The following is a description of a gene set: Human Gene Set: MODULE_198 Genes in the cancer module 198. studied in species Homo sapiens, and this is the list of marker genes: HNRNPF, POLE, XRCC3, CBX4, GTF2I, PHLDA1, PSMC4, SNRPA1, HIF1A, KRT19, FOXD1, KATNB1 (NCBI Gene Id 10300), STAMBP, ZNF43, TOPBP1, NCBP2, TRIP13, PPP4C, CBX5, FKBP5, CENPF, CDC7, SLBP, MCM3, PSMA4, ZBTB25, MAZ, BRD2, CDC5L, MSX1, RNMT, RAD51D (RAD51 paralog D), CCNT1, E2F1, PRKDC (protein kinase, DNA-activated, catalytic subunit), TOP2A, TLX2 (T cell leukemia homeobox 2), CDK1, RFC1, CCNA2, NEK2, CEBPG, RAN, ZNF124 (NCBI Gene Id 7678), CHAF1B, RPA3, HNRNPR, BLM (BLM RecQ like helicase), NME2, FOXG1, CCNB2, CCNE1, UNG, TULP3, BARD1, RAD21, CCNB1, BLMH, NASP, NFATC4, PSMD2, RBBP7, CDC45, DDX23, ZWINT, HSF2, PSMA2, MSH2, DNMT1, ZNF195, ASAP2, RNF144A, POLR2D, FEN1, KRT6B, AP3M2, BMI1, KNTC1, SRSF2, MYCN, APEX1, SMARCC1, LRP8, CCND2, PTTG1, SRPK2, WEE1, PRPF8, LIG1, CALU, EWSR1, RFC5, SNW1 (SNW domain containing 1), NDC80, MAP2, SPDEF, MAFG, MLF1, MYBL2 (NCBI Gene Id 4605), CCNE2, CDKN1A, RBBP8, CDK7, HNRNPA3P1, CSE1L, DLX5, H2AZ1, ZIC1, ATF4 (activating transcription factor 4), PSMD10, PPP2R5D, HDAC2, PRIM1, PER1, MYC, DUSP5, ACTL6A, KRT17, AKT1, HMGN4, LMNB1 (NCBI Gene Id 445266), H2BC12, POLA1, SATB1, MYO18A, KIF23, H2AX, NAP1L4, NUP107, POU4F1, TENT4A, RCC1, SRSF6, CTCF, FANCG, CHEK1, DR1, CCNA1, CMPK1, TFAP2A, TAF6 (NCBI Gene Id 6878), RBBP4, PRIM2, UBE2A, RECQL4, CDK2, FOSL1, VPS72, RPA1, SRSF1, TRA2B, SSB, SETDB1, STK38, TBP, CDKN2C (cyclin dependent kinase inhibitor 2C), DDX17, NME1, MNDA, XRCC5, ILF2, TMPO, RAD51C, SAP30 (Sin3A associated protein 30), MAPK14, ZNF217, COIL, ZFP36L1, LIG4, CENPA, SUMO1, SMC2, FUS, CDC25C, NUP153, CSNK2A1, HNRNPC, PLK1, JUNB, NEK4, APLP2, SNRPC, KHDRBS1, PSMB5, PSMD12, GTF3C2, POLE2 (NCBI Gene Id 5427), POP7, SFPQ, RFC2, YBX1, LSM1, TNPO1, HMGB1, TCF12, POLD2, GNL2, HR, RNF4, JUN, DSP, ORC1, TFDP1, MYT1, TAF4 (TATA-box binding protein associated factor 4), PAX6, RUNX3, DDX5, EZH2, CBX1, HNRNPA0, SRSF10, RPA2, GFI1, GTF2F2, TLE1, COPS2, KIF2C, MTA1, SOX9, CDKN2A, SLU7, PTMA, ANP32A, FOXM1, LMO2, PTTG1IP, ADAR, NCAPD2, CHD4, IPO7, NFYA, KIF22, RFC4, BUD23, CLK2, GTF2A2, STAT1, ADNP2, DHX9 (NCBI Gene Id 3450), LHX2, ILF3, KMT2A (lysine methyltransferase 2A), CSRP2, POLR2K (NCBI Gene Id 5440), RAD51, MCM6, HNRNPH2, ZNF146, POLD1, TGIF1, CENPE, MAD2L1, CCNO, RAD23A, DYRK1A, DEK (DEK proto-oncogene), SNRPE, ACTR1A, H2BC21, TAF11, SNRPB2, HOXA13, SSRP1, KMT2D, KPNB1, NUTF2, STMN1, MPHOSPH6, SRSF7, CSTF3, THOC1, DGKI, HLTF, PNN, NELFE, PRP4K, PSMC6, HMGB2, NAP1L1, ESPL1, TSN, BUB1, RAD54L, HDAC1, FOS (Fos proto-oncogene, AP-1 transcription factor subunit), RFX5, E2F3, SNRPD1, MLH1, TAF7, ATN1, MEIS1, SOX4 (NCBI Gene Id 6659), RFC3, KHSRP, INSM1, BCL9, HAT1, CHAF1A, PCNA, POLR2F, DCK